Given this list of marker genes E2F5, IFT25, PSMD7, CRYBG1, PPIP5K2, PAFAH1B1, KMO, ZSCAN12, TCF3, SRP19, DLEU2, RASGRP1, MYH6, HNRNPH2, KIDINS220, CLINT1, SLK, TAOK3, ABI1, SRSF9, EIF4H, CCK, INSIG1, PPP1R12A, PTPN11, VLDLR, ARAP2, MNAT1, RNF24, MYL12A, IGF2, SECISBP2L, CCDC69, NUP160, PTPRC, FAM3C, SH3GLB1, CPNE3, NDUFA2, CLASP2, DUSP11, FTO, YWHAZ, RCBTB2, NOS1, MNDA, DSG1, ARCN1, ABHD3, UPF2, DHX9, LRIG1, SLC25A3, DHRS12, SUCLA2, RBPMS, THRA, DYRK3, HNRNPA3, MED6, DLD, USPL1, SLC35B1 (solute carrier family 35 member B1), ZHX2, CHMP2B, VNN2, PIK3CD, DHRS7, FCGR2A, PIBF1, GTF2B, PMAIP1, CLIP1, TXNDC9, IFIT5, SERTAD2, FUBP3, CALM3, LINC00342, NAGPA, SEC11A, TCF12, LAMP2, LDLRAD4, ANXA7, CREBBP, XRCC5, MRPS27, HNRNPR, LSM6, KRT12, LARP7, SRY, HSPA4, PRKAR1A, RABGAP1L, APAF1, NFYB, ACTR2, RIOK3, OGT, GOSR1, SLC39A8, ZNF43, E2F2, PTGDS, PSMD12 (proteasome 26S subunit, non-ATPase 12), PSME2, RSAD2, SNRPG, PSD3, RARRES1, NAP1L1, GNG10, TCF20, SRPRA, PSMA5, GTF2A2, SNAPC5, UBA3, SUZ12, IGKC, C6orf120, RB1CC1, MAP1LC3B, SRSF11, RBM34, MGAT2, MICU2, WASHC4, COIL, DOCK2, HMGN4, SEC24A, ITIH1, ELOC, PRPF18, TOB1, PLAG1, RUNX2, UBE2L6, DCTN6, PSMD1, CDC40, MTMR1, CGRRF1, MEGF9, MAP3K5 (NCBI Gene Id 4217), SERINC1, HSPA13, TBX6, FAM76A, SELENOF, GNE, ADAM17, EXT2, CLDN18, LEPROTL1, RCHY1, PRIM2, TERF1, TMED5, KRIT1 (NCBI Gene Id 9602), MT1G, KNOP1, ABL1, CD9, TOR1AIP1, PIKFYVE, COQ2, DLEC1, RNF144A, SEC63, BACH1, PAIP1, CRIM1, NDC80, CBX3, ABAT, CLP1, SEC61B, PSMC6, PIK3C2B, PLA2G4A, HPCA (NCBI Gene Id 3208), EID1, SPTLC1, SC5D, PDCD6, TPP2, PTPRK, IGHV5-78, WT1-AS, IFI16 (NCBI Gene Id 3428), RYK, PPP3CA, BCLAF1, CD55, SMAD1, CASP1, PHLPP1, HNRNPA1, TSNAX, LAMTOR5, WNT7A, HMGCR, HCRTR1, MORC3, PGD, GRB14, FASLG, MSH6, UBE2J1, RSU1, NSA2, DCK, NIPA2, MMD, STX12, ANAPC10, PRKAR2B, RYBP, FDFT1, SNRK, SLC35A1, RBL2, HIBCH, SUN1, ADAM19, HSPA5, SET, ZMYND11, NFE2, PARG, YWHAQ, SEC24B, MRPL33, MEGF8, NF2, ASS1, PDE8A, IGFBP5, IRF4, NCKAP1L, DDX5, KIN, DDX46, PTMA, RPL29P17, EVI5, OAS2, UBE2G1, STX8, C1D, TPD52, ZFAND5, TAX1BP1, MAGOH, CYB5B, ZPR1P1, SUB1, CDK2AP1, RAB21, ELMO1, CALM2 (NCBI Gene Id 805), PRDX1, TWF1, TMED2, CAPZA1, ARID4A (AT-rich interaction domain 4A), PHF2, CIB2, RTCB, SUMO4, ADCY1, SIRPA, SERINC5, SP100, DYNLT3, SKP1 (S-phase kinase associated protein 1), ETS2, SEC61G (SEC61 translocon subunit gamma), BBIP1, GPN1, PSMA3, UBR2 (NCBI Gene Id 255838), POLR2B, PSMA1 (NCBI Gene Id 5682), TBCA, NT5C2, RPN2, TRA2B, ADK, IL6ST, JCHAIN, COX7B, CREG1, EXO1, SCML1, MPPE1, CHUK, BCAM, NXT2 (nuclear transport factor 2 like export factor 2), SMARCE1 (NCBI Gene Id 6605), NEMP1, CYP27A1, IGBP1, SRP9, SDCBP, PPP1R2, LDLR, NPTN, NRGN, POU2AF1, PLCL2, R3HDM1, DMXL1, UQCRB, HAT1, ZNF217, HIPK1, ATN1, PDS5B, FANCC, CD2AP, EOLA1, SERPINI2, GLO1, LYSET, CMTR1, COPS8, USO1, MBNL1, DYRK1A, IK, COX7A2L, EIF5, SMARCA5, EIF3M, SOCS6, SEM1, UBE3A, EIF2S3, DNAJB12, EP300, UQCRC2, PTPRG, ATP5MJ, MINPP1, FGFR2, PRPSAP2, CDC123, IDI1, ZFX, REV3L, KCNAB1, TOX4, SSTR5, RABIF, SMG1P5, RAD52, MSMO1, USP33, C5orf15, TRAF3IP3, EPHA5, CACYBP, BET1, ZNF273, SLC30A9, RTN4, SAT1, ADH6, CXCL1, TDRD7, CIR1 (NCBI Gene Id 9541), TRA2A, MAP2K4, VPS26C, CDK18, SPTLC2, PRPH, MED25, PURA, PRKY, KLF4, PAK2, CDH8, STT3A, UBC, SLC25A5, ADAM10, TOMM7, TBC1D1, BTF3P11, FCN3, PDCD10, TP53BP2, AIMP1, TGM2, GAS7, RCN2, ACYP2, SNX2, HPS5, IL7, SSUH2, OR2H2, SPTSSA, PPIG, HMGN3, RSRP1, SNAPC1, MYOF, BAZ2A, ATP5PF, RAB5A, MANBA, PRKACB, RGS4, MMP7, ICAM2, RP2, DIS3, COL4A2, MICB, ATP5MF, NMT1, SQLE, SYPL1, AP3D1, BZW1, CCNH, PPP1R8, RAD23B, SEL1L3, EPB42, GABARAPL2, RNF6, CAT, PPM1A, SEC13, ATRNL1, DAP3, RAB1A, CUL4A, DCLRE1A, ATP6AP2, AZIN1, NDUFA5, ERH, GPM6A, SEC62, DOP1B, SMNDC1, ELOVL5, SRP54, FAM8A1 (NCBI Gene Id 51439), SNRNP200, HMGN1, COBL, HNRNPA2B1, PPWD1, CBX1, ASPHD1, SEC23A, PIK3R3, SRSF5, GALNT1, BMI1 (BMI1 proto-oncogene, polycomb ring finger), MAGEA2, HACD2, LSM14A, GMFG, SMC5, SNRPB2, VEGFA, EFS, EDEM1, ABCF2, TRIM9, RBBP4, LY96, SRGAP2, HMCES, SNRPE, DSTN, TBCE (NCBI Gene Id 6905), OVOL3, PPM1B, COPS5, PTP4A2, TCAP, KIFAP3, ACSL4, LYZ, EED, PEX2, TMEM59, CRY1, TASOR, PRRC2C, ZEB2 (zinc finger E-box binding homeobox 2), ITSN2, EIF1, RWDD3, LRRC14, CDK7, MTDH, GCH1, BCL7A, KDM4A, XPA, YTHDC1, PTP4A1, COPB1, ANP32A, ATAD2B, MDH1, PHF3, NDUFS4, EVI2A, PPP3CC (NCBI Gene Id 5533), NDST1, POLR2J, EIF2AK2, COX7A2, NCOA2, KLHL23, ANXA2P1, CBR4, WDR7, WARS1, KTN1, EPS15, YAF2, PCMT1, RAP1B, COX6C, RNF11, FBLN1, TDP2, TMSB10, TMSB15A, PLXNC1, LANCL1, SERINC3, ASNS, LAMC1, LRP1, MRFAP1L1, SEPTIN6, CAST, GMFB, KALRN, SSBP2, ATF4, ADH5, SLC16A4, LILRB4, ZNF207, SGCE, MYCBP2, ISG20L2, SCP2, EIF3H, NEK7, TNNI3 (NCBI Gene Id 7137), GOLGA4, KRT19, ATP8A1, COL21A1, ADD3, SLC35E2B, PIM2 (Pim-2 proto-oncogene, serine/threonine kinase), PEX19, JAG1, SACM1L, PPFIA1, EEF1B2, ACADM, ITGB3BP, MARCHF7, CD164, GLRX, PSIP1, ADCY8, YME1L1, DECR1, PGGT1B, CCNG2, TOPBP1, PJA2, RAP1A, LEF1, GTF2E2, RALBP1, PGK1, GLUL, EIF4G3, TAF5L, STK3, ATP11B, ATP6V1G1, PSMD6, RAD17, H2AZ1, HLTF, OAS1, NSL1, PTPN13, RAD21, ENSG00000240291, ASMTL, RFK, PDZK1, VDAC3, ZBTB1, MCFD2, GAPDHS, HNRNPA0, ANKRD28, CTH, GSDME, ATF2, STRAP, LPGAT1, NCBP2, TBCC, TRAM1, SUMO1, RUNDC3B, ABCB10, TCEA1 (NCBI Gene Id 7865), ZFYVE16, CANX, MYL3, PSMD10, MSH2, NECTIN3, BECN1, PRDX3, TMEM123, SF3B1, RB1, HS2ST1, ECH1, NFE2L2, EIF2S2, SLIT3, WTAP, CLIC4, MYD88, FBXW11, SOS2, NHLH1, UTP3, TOR1B, HGF, PSMA4, MEF2A, SRRM1, CSH1, HEXB, H2AZ2, MBD2, MBD4, STXBP3, PPP6C, ATP6V1C1, TFE3, TFAP2A, CEP68, ARSL, SDHD, NIPSNAP2, LY75, TOGARAM1, BLNK, NMI, PMP2, PCDH11X, GLMN (glomulin, FKBP associated protein), MTMR9, TOP2B, FMR1, CLEC4M, SREK1IP1, DMXL2, ADARB1 (adenosine deaminase RNA specific B1), PKP4, NBN, QPCT, DIAPH2, PDK4, ZBTB18, SEC24D, ARIH1, AKAP12, CDC7, INSR, STAT1, ATP2A2 (ATPase sarcoplasmic/endoplasmic reticulum Ca2+ transporting 2), ANP32E, ARFGEF1, PHGDH, here is a description of the gene set: Proliferation of higher eukaryotic cells is triggered by the proto-oncogene c-myc (myc), which is induced downstream of a large number of growth factor receptors. Myc, a basic helix-loop-helix leucine zipper transcription factor, transmits growth signals by up- and downregulation of target genes. The importance of Myc in growth control is well established. However, the number of growth control genes requiring Myc as an essential factor for regulation after mitogenic stimulation of cells is not yet clear. Here, we have studied the transcriptional programme of a human B-cell line, P493-6, in response to Myc and serum. P493-6 cells do not express the endogenous myc, nor is it induced by serum stimulation. Proliferation of the cells is dependent upon both the expression of a tetracycline-regulated myc gene and serum stimulation. Using DNA microarrays, expression profiling was performed following stimulation of cells with serum, with Myc, or with both. We observed serum regulation of >genes. A number of these genes were synergistically or antagonistically regulated by Myc. Moreover, we identified >300 Myc-regulated genes that were almost unresponsive to serum. Gene ontology analysis revealed that a high proportion of Myc target genes are involved in ribosome biogenesis and tRNA metabolism. The data support our current notion that Myc is essential for the regulation of a large number of growth-related genes in B cells, and cannot be replaced by other serum-induced factors. Cluster 4: genes down-regulated in B493-6 cells (B lymphocytes) upon serum stimulation but not affected by MYC. Human Gene Set: SCHLOSSER_SERUM_RESPONSE_DN species: Homo sapiens from publication Schlosser I, Hölzel M, Hoffmann R, Burtscher H, Kohlhuber F, Schuhmacher M, Chapman R, Weidle UH, Eick D (PMID 15516975)